Given this list of marker genes NDUFS6, RPA1, RAB2A, AKR1B1, MOAP1, FHDC1, ATP6V0E1, DNAJA4, TIPIN, PPEF2, AEBP2 (NCBI Gene Id 121536), UBR5, RPL23, CISD1, ATP5ME, CHMP4B, NDUFB7, DPY30, S100A10 (S100 calcium binding protein A10), GLRX3, HPRT1, EGR1 (early growth response 1), NDUFV3, BCL2A1, F2R (coagulation factor II thrombin receptor), UBE2G1, KRAS, AIFM1, UBE2J1, SLC25A36, TMBIM1, COX4I1, PRRC1, NDUFA2, COP1, TRAPPC1, SF3B2, CENPA, NFU1, SNRPC, SEPTIN6, TEX2, MRPL35, ENSG00000286190, UQCRB, COX20, LRRC59 (leucine rich repeat containing 59), HIF1A, WSB2, NDUFA1, RABGAP1L, PDE12 (NCBI Gene Id 201626), COA6, METAP1, PURB, ATP6V1E1, EZH2, AMMECR1L, TMEM160, EGR2, SAR1B, EI24, CSNK1D, NDUFC2, LIG1, TMEM165, SFR1, NDUFC1, FDX1, CASP3, TTC33, TNKS2, ARPC5, ATXN1, GHITM, UGP2, UBE2F, DDT, RNASEH2C, PRNP, PFN2, EFHD2, SPCS1, CCT2, ORMDL1, RAB10, NAA30, TMEM9B, VPS29, EMC6, GNG2, TMPO, TP53INP1, NUCB1, PTPN11, ATP6V1A, RPS26, CMIP, MPC2, HACD2, ACP1, UBE2E1, NDUFB5, NUCKS1, SUMO3, LIMD2, HMGB3, IDE, RAB40C, UGDH, TMEM19, ABHD4, NDFIP1, ERMP1, MRPL51, PSMA3, ADAT2, RBL1, MRRF, DBF4, TXN, PYCR2, CAPZB, YWHAQ, FEM1B, PSMA5, MRPS18C, FAM20B, M6PR, COX6A1, PPP1R11, CETN3, EEF1D, RAB29, TBCB, STK26, ELOC (NCBI Gene Id 6921), VAMP4, ATP6V1C1, RNF19A, PTP4A2, GATD3, S100A4, VBP1, FAM8A1 (NCBI Gene Id 51439), EIF4ENIF1, UQCR11 (NCBI Gene Id 10975), AP3S1 (adaptor related protein complex 3 subunit sigma 1), ROCK1, EIF2S3, LARP4B, IRAK4, FBXO45, PLAGL1, MYL12B, ERO1A, RAP2A, DDIT4, MARCHF7, CTNNB1, UBE2D3, TIMM17B, SERINC3, CSTB, SLAIN2, ZFP91, TMEM223, BNIP3L, SUCLA2, SEC11C, NDUFA11 (NCBI Gene Id 126328), NDUFB3, ODC1, LITAF, RBM18, GOLGA4, CUX1, ZFPM1, H2AX, CEBPG, SASS6, CMAS, MOB1A, SMC5, SEC23B, ATP5MC3, MARCHF5 (NCBI Gene Id 54708), JARID2, MARCHF6, SF3A2, TMCO1, GOSR2, ALYREF, RBM10, COX5A, CNIH4, FAM32A, DDX3X, CD160, TMEM30A, here is a description of the gene set: species: Homo sapiens To clarify inflammatory genes whose expression is suppressed at high temperatures, we performed comprehensive analysis of gene expression by using a DNA microarray. Two independent primary cultures of mouse embryo fibroblasts (MEF1 and MEF2) were treated with LPS for 4 hours, or treated with LPS for 4 hours after the pretreatment with heat shock at 42˚C for 1 hour, and we identified genes that undergo more than a 3-fold increase with LPS treatment. Remarkably, genes (86%) underwent less than a 2-fold increase after combined treatments with heat shock and LPS in MEF1 and MEF2 cells. Genes up-regulated inmouse embryonic fibroblasts (MEF): control versus LPS and heat shock. from publication Takii R, Inouye S, Fujimoto M, Nakamura T, Shinkawa T, Prakasam R, Tan K, Hayashida N, Ichikawa H, Hai T, Nakai A (PMID 20018623) Human Gene Set: GSE16266_CTRL_VS_HEATSHOCK_AND_LPS_STIM_MEF_UP